Given this list of marker genes TTYH1, ANO9, ANO1, ANO2, ANO5, BEST3 (NCBI Gene Id 84821), CLCA1 (chloride channel accessory 1), ANO3, ANO8, CLCA4, ANO6 (anoctamin 6), ANO7, CLCA2, ANO4, NMUR2, TTYH2, TTYH3, ANO10, BEST4, BEST1 (NCBI Gene Id 7439), here is a description of the gene set: Human Gene Set: GOMF_INTRACELLULARLY_CALCIUM_GATED_CHLORIDE_CHANNEL_ACTIVITY Enables the transmembrane transfer of chloride by a channel that opens in response to stimulus by a calcium ion or ions. Transport by a channel involves catalysis of facilitated diffusion of a solute (by an energy-independent process) involving passage through a transmembrane aqueous pore or channel, without evidence for a carrier-mediated mechanism. studied in species Homo sapiens